Given this list of marker genes DLG4, GPHN, SHISA6, FRRS1L, GLRB, LHFPL4, SHISA7, APOE, SHANK3, NLGN2, NRXN1, SSH1, NLGN1, ZDHHC2, CHRDL1, SLITRK3, SLC7A11, RELN, here is a description of the gene set: The receptor clustering process in which neurotransmitter-gated ion channels are localized to distinct domains in the cell membrane. Human Gene Set: GOBP_NEUROTRANSMITTER_GATED_ION_CHANNEL_CLUSTERING studied in species Homo sapiens